Given this list of marker genes Eps15l1, Ptpn12, Spry1, Ereg, Arhgef7, Epn1, Stam, Rps27a, Ubb, Cdc42, Uba52, Sh3gl2, Sh3gl1, Hbegf, Hgs, Sh3gl3, Cbl, Stam2, Areg (NCBI Gene Id 11839), Sh3kbp1, Eps15, Ptprk, Epgn, Spry2, Egf, Grb2, Ubc, Egfr, Btc, Ptpn3, Tgfa, Uba52rt, here is a description of the gene set: Mouse Gene Set: REACTOME_EGFR_DOWNREGULATION studied in species Mus musculus EGFR downregulation